The following is a description of a gene set: Human Gene Set: GOBP_POSITIVE_REGULATION_OF_CELL_JUNCTION_ASSEMBLY Any process that activates or increases the frequency, rate or extent of cell junction assembly. species: Homo sapiens, and this is the list of marker genes: SFRP1, CAV1, CRB3, SMAD3, DLG5, SLITRK5, S100A10, LIMS1, EPHB3, GPRASP3, SLITRK2, STAU2, AGT, SRPX2, THBS2, NRP1, CFL1, FLRT2, CLSTN1, CUX2, TBX5, EEF2K, LINGO2, ADGRB2 (adhesion G protein-coupled receptor B2), CBLN1, POLDIP2, ADNP, NPHP1, IL17A, RAC1, AGRN, TPBG, ADGRB1, FERMT2, CLSTN3, PTPRD, PTPRJ, ROCK1, ASIC2, CLDN1, SYNDIG1, SLITRK1, AMIGO3, FLRT1, COL16A1, FLOT1, LRRTM2, LRRTM3, CNTNAP2, GHRL, SLITRK4, IL1RAPL1, MYOC, THY1, VSTM5, NTRK3, CLSTN2, IQSEC2, ARMCX5-GPRASP2, ADGRB3, EPHA2, SDC4, ITGB1BP1, LRRC4B, AMIGO1, DSG3, NLGN1, LRRN1, KDR, BDNF, WNT7A, ST8SIA2, NLGN2, EPHB1, MAP4K4, AMIGO2, WNT4, FLRT3, GDF2 (NCBI Gene Id 51423), PRKCA, NTRK2, SEMA4D, IL1RAP, SLITRK3, OXT, HOPX, GRID2, LRRN3 (NCBI Gene Id 92468), HRG, TEK, EPB41L5, EFNA5, ABL1, TSC1, CLDN5, SLITRK6, VEGFA, LINGO4, SEMA4A, LRTM2, CBLN2, NRXN1, LRRC24, NLGN3, NPHP4, ACE2, PPM1F, EPHB2, IRX3, LRRTM1, ACVRL1, NTRK1